Given this list of marker genes MEFV, IL1RN, TLR3, ARPC5, PIK3CD, TET2, ASXL1, RELB, CSF3R, UNC93B1, IRF8, OTULIN, KIT, TRAF3, MVK, RAC2, ZNFX1, IL36RN, PTPN6, SRSF2, TBK1, SLC35C1, TICAM1, here is a description of the gene set: Abnormal increase of absolute number of neutrophils in the blood, per microliter, compared to a reference range for a given sex and age-group. Increased total neutrophil count Human Gene Set: HP_INCREASED_TOTAL_NEUTROPHIL_COUNT studied in species Homo sapiens